The following is a description of a gene set: Abnormal rib cage morphology Human Gene Set: HP_ABNORMAL_RIB_CAGE_MORPHOLOGY A morphological anomaly of the rib cage. studied in species Homo sapiens, and this is the list of marker genes: PPP3CA, MYF5, UBE3B, CPLANE1, CENPJ, NXN, CHD7, CSPP1, NOG, PRKACB, EXT2, RPS19, OBSL1, CRTAP, PRDM16, SBDS, DLK1 (NCBI Gene Id 8788), CPLX1, MESP2, TOR1A, DYNC2LI1 (dynein cytoplasmic 2 light intermediate chain 1), KDELR2, CEP152, UBA1, TGIF1, INTU, HNF1B, RSPO2, GALNS, FUCA1, PAX7, RUNX2, RBM8A, WASHC5, EVC, IKBKG, EBP, HRAS, COL11A2, FGF8, SNX10, CCDC8, ATP6V1B2, FBN1 (NCBI Gene Id 7470), NUP88, GNPTAB, SOX9 (SRY-box transcription factor 9), HOXD13, DLL1, SUFU, LAMA5, DNM2, FOXF1, FLI1, ZMPSTE24, SIX3 (NCBI Gene Id 6496), SPRED2, JAG1, BANF1, SOX2, P3H1 (NCBI Gene Id 64175), NALCN, LMX1B, FLNA, WNK3, RNU4ATAC, TRPV6, CDC45, TNFSF11, LMOD3, AKT1, ZIC2, GPC4, NSD2, HGSNAT, TTC21B, BMP1, ORC6, RRAS2, GNS, COL1A2, COL13A1, TOMM7, RYR1, PIGG, LRP5, SPEN, CLCN7, RTL1, COL2A1, CSF1R, SERPINH1, GLI2, HERC1, TENT5A (NCBI Gene Id 55603), SLC26A2, MGAT2, MAN2B1, NKX3-2, SF3B4, KIAA0586, ATP7A, NEK1, PTPN11, RMRP, SRCAP, DYNC2I1, PRKCZ, KIAA0753, GUSB, RRAS, IFT43, IFT140, TRAPPC2, ACTA1, SIX6, VPS35L, WNT1, TGFBR1, SOS1, NODAL, CUL7, NAGLU, DYNC2H1, NEK9, FGFR3, TBX5, B3GAT3, FGFRL1, LFNG, POLR3A, CDC6, PAX3, USP18, CBL, ANKRD11, DPYSL5, LIFR, B4GAT1, ROR2, HHAT, CHST3, DYNLT2B, GLB1, RERE, VPS33A, SNRPB, ADAMTS10, KLHL41, DLL3, GLI3, NEB, KYNU, NAA10, FUZ, EIF2AK3, SCARF2, SLC26A1, DHCR7, FRAS1, CFAP410, TBX15, RECQL4, GDF6, MYH3, UBE4B, PHEX, IDH1, SON, CTNS, EZH2, NIPBL, C2CD3, COL11A1, PLCB3, CCDC22, SP7, POP1, ATR, NFASC, FOXH1, HES7, DONSON, TRIP11, GAS1, BGN, IRF6, BRD4, CTBP1, KAT6A, STIL, MEOX1, TRPV4, ABCD4, LBR (NCBI Gene Id 653311), SMAD4, ANTXR1, GATA4, MTMR14, COL10A1 (NCBI Gene Id 93042), EFL1, CHRNG, KCNAB2 (NCBI Gene Id 8514), ABCC9, HNRNPR, PEX1, P4HB, CEP120, LRP4, MTX2, TAPT1 (NCBI Gene Id 202018), DHCR24, AFF3, PRKACA, MAPK1, PCYT1A, B3GALT6, APC, SEMA3E, VDR, MYF6, SMO, CANT1, RNU4-2, GMNN, TBCK, ALPL, IDUA, AIFM1, ANK1, SHH, CILK1, LUZP1, WNT7A, CDC42BPB, PTCH1, IFT80, IFT172, DISP1, DYNC2I2, SETBP1, IGF2, FIG4, TNFRSF11A, TCIRG1, SLC34A1, ARSL, DNAJC21, SOST, WDR35, PCGF2, AR, CREB3L1 (cAMP responsive element binding protein 3 like 1), NRAS, GPX4, MATN3 (NCBI Gene Id 4148), WNT3, IDS, MAF, FLNB, INPPL1, BMPER, OCRL, CHRNA1, ODC1, MUSK, WDR19, SH2B1, SCN4A, SKI, SELENON, LETM1, RIT1, SCUBE3, MEG3, FGFR2, PTH1R, ALDH1A2, NELFA, EXT1, COG1, SLC34A3, ORC4 (NCBI Gene Id 5000), TBCE, TFE3, KLHL40, ESCO2, IGF1R, H19, PLOD1, DACT1, ORC1, GDF11, IFT122, CRIPTO, RNU12, RAF1 (Raf-1 proto-oncogene, serine/threonine kinase), CHD6, TBX6, CYP2R1, PRIM1, PDGFRB, SGSH, PDPN, DDRGK1, PUF60, TMEM53, GLE1, VAC14, CA2, FREM2, TBC1D24, LMNA, IL1RN, RTTN, GABRD, ALG12, TMCO1, RAB5IF, XYLT1, IFT81, SLC35D1, HSPG2, XYLT2, BCOR, GDF3, GNPNAT1, ERMARD, KCNQ1OT1, PAM16, ARSB, KRAS, EFNB1, COL1A1, SRP54, RAB33B, AMER1, PTDSS1, ACP5, FAM111A, VANGL1, MRAS, KMT2A, TBX4, SEC24D, AHDC1, ARSK, WNT4 (NCBI Gene Id 54361), ACAN, MESD, DYM, RASA2, BIN1, GATA6, CCN2, LZTR1, SF3B2, CHRND, CASZ1, CYP27B1, RPS26, BMP2, COMP, ACTB, SALL1, DDR2, MMP13, SOS2, GPKOW, GRIP1, MAMLD1, CSGALNACT1, IFT57, NSDHL, HDAC6, TNFRSF11B, ADA, EXOC6B (exocyst complex component 6B), PPIB, GPC3, KCNJ8, PRKG2, RIPPLY2, PAICS, CDON, CDT1, IHH, MGP, MMP23B, CHRM3, POR, MAP2K1, MTM1, DNMT3A, MAP3K7, FERMT1, PTCH2, EVC2, BRAF, PORCN